The following is a description of a gene set: Human Gene Set: MIR4717_5P from publication Chen Y, Wang X (PMID 31504780) Genes predicted to be targets of miRBase v22 microRNA hsa-miR-4717-5p in miRDB v6.0 with MirTarget v4 prediction scores > 80 (high confidence targets). species: Homo sapiens, and this is the list of marker genes: STC1, PDE7B, CEP350, ZEB1, FSD1L, LSM8, PDIA6, TMEM151B, STARD13, AKIRIN2, SCCPDH, CHMP7, SERPINB6, CRACD (capping protein inhibiting regulator of actin dynamics), TCF12, DOP1A, NACA, SLMAP, ATP6V1A, FBXO42, ZNF133, NR2E1, MAGI3, ATF7, ZBTB41, LSM10, ELAPOR1, EFTUD2, ATP8A2, RHO, EPAS1, SOS2, CLIP2, GAS2L1, SDC2, RBPJ, BCLAF3, GANC, AGFG1, PARP16, GDAP2, IRF2BP2, KIF1B, HERC4, GRM5, NAP1L3, VGLL4, EGLN1, PAX5, HADHB, BNIP3, RAB3C, XYLT1, PPT2, ABCF1, ZBTB20, MFSD14A, TRIM33, MAP3K19, TSHR, FYCO1, GET1, PLPP3, GALNT7 (NCBI Gene Id 51809), GPR65, PGGT1B, ERG, COL23A1, LMNTD2 (NCBI Gene Id 256329), LRP10, GDI1, TES (NCBI Gene Id 26136), SLC35A2, KDM3B, IGSF5, MAPRE1, CDC42BPB, SLC25A36, SNRPB, WWC1 (NCBI Gene Id 23286), LMBR1L, CSKMT, SCRN1, MINK1, ELL2, ADIPOR2 (adiponectin receptor 2), SRSF2, BCLAF1, ASAP1, ST6GALNAC4, TRIP11, KCNQ3, PEAK1, KMT5B, TRHDE, VCAM1, SMIM17, CDH9, SUB1, TMEM64, NRIP3, NUDT7, FYN, RAB10, FKBP1A, SEC16A